Given this list of marker genes R3HDM1, WWP2, CASZ1, EBF3 (EBF transcription factor 3), C1R, ABI2, POLR3K, AFF1, KLF8, FGR, MKRN1, COPS2, ELL, ZNF561, ADRB3 (adrenoceptor beta 3), DOK2, KCMF1, ZNF704, TNRC6A (NCBI Gene Id 92763), PAWR, MEST, PRR13, COL4A3, SH2D1B, ACAP2, POU1F1, YBX1, HCN4, CHN2, TMEM245, TTR, WIPF1, ERAP1, COL6A6, ACSL6, PLXNC1, PIK3CA, NDST3, PRKCA, DLG4, GTF2IRD2, AKR1B15, GTF2IRD2B, RTN4RL1, NDUFA4, QKI, NWD1, RPL26L1, OSBPL3, LPGAT1, PAPSS1, DUSP28, WDR7, DNAI4, HP1BP3, CSDE1, PHF6, YWHAB, FAM228A, LINC03034 (NCBI Gene Id 648835), PRUNE2, ITPRID2, RLIM, CHRNA3, NCOR1, ELF1, SLC25A53, THTPA, ZBTB20, GNRHR, SLC25A30, ZNF492, NAGLU, ARID4A, E2F5, DYNAP, DBX2, SSU72, ACTL6A, SLC11A2, HPSE, MGAT2, MYLK3, PDE7A, RNF13, TMEM132C (transmembrane protein 132C), SMIM15, CRISPLD1, ACIN1, TM2D2, NUFIP2, ADAMTS6, AKR1B10, MMP2, here is a description of the gene set: from publication Chen Y, Wang X (PMID 31504780) Genes predicted to be targets of miRBase v22 microRNA hsa-miR-12117 in miRDB v6.0 with MirTarget v4 prediction scores > 80 (high confidence targets). Human Gene Set: MIR12117 studied in species Homo sapiens